Given this list of marker genes Ankrd13a, Atxn2, Sdcbp, Anxa2, Pcsk9, Lrrtm2, Ankrd13d, Ankrd13b, Mtmr2, Wdr54, Fmr1, Lrrtm1, Rin3, Necab2, Lrpap1, Ubqln2, Dlg4, here is a description of the gene set: Any process that stops, prevents, or reduces the frequency, rate or extent of receptor internalization. Mouse Gene Set: GOBP_NEGATIVE_REGULATION_OF_RECEPTOR_INTERNALIZATION studied in species Mus musculus